Given this list of marker genes Fgb, Map9, Gm23644, Gm24150, Ctso, Dnmt3a-ps1, 6430573P05Rik, Rapgef2, Gm20356, Rbm46os (NCBI Gene Id 78212), Gm36569, Gm9762, Wdr49, Fga, Gm4857, Npy2r, Serpini2, Gm30097 (NCBI Gene Id 102631873), Fstl5, A830029E22Rik, 4930509J09Rik, Sfrp2, Gm29808, Gria2, Gm10291, Gm18719, 4921511C10Rik, Rbm46, Glrb, Zbbx, Gm7115, Gm5277, Fnip2, Gucy1a1, Dchs2, Plrg1, Gm38353, Gm29999 (predicted gene, 29999), Gm6677, Gm18952, Gm23440, Gm35067, Gm8625, Gm10710, Gm9989, Spmip2, Rpl28-ps2 (NCBI Gene Id 100045518), Sis, Gm22531, Asic5, Gm6706, Mir7010, Gask1b, 4930589L23Rik (RIKEN cDNA 4930589L23 gene), Pdgfc, Rxfp1, A330069K06Rik, Gm17836, Gm19066, Slitrk3, Fgg, Platr10, Tmem144, Lrat, Gm6680, Gm26420 (predicted gene, 26420), Gm8684, Gm35323, Gm19231, Gm22451, Gm25846, Gucy1b1 (NCBI Gene Id 54195), 4930579G24Rik, Gm18428, Tdo2 (NCBI Gene Id 99471), Bche, Gm6098, Ppid, Serpini1, Gm30043, Etfdh, Pdcd10, Tlr2, Golim4, 1700028M03Rik, Gm17953, Gm15442, Gm8643, here is a description of the gene set: Mouse Gene Set: chr3E3 species: Mus musculus